The following is a description of a gene set: Genes gradually down-regulated by histamine in B16-F10 melanoma tumors. Mouse Gene Set: POS_RESPONSE_TO_HISTAMINE_DN from publication Pos Z, Wiener Z, Pocza P, Racz M, Toth S, Darvas Z, Molnar V, Hegyesi H, Falus A (PMID 18339882) studied in species Mus musculus We previously showed that transgenic enhancement of histamine production in B16-F10 melanomas strongly supports tumor growth in C57BL/6 mice. In the present study, gene expression profiles of transgenic mouse melanomas, secreting different amounts of histamine, were compared by whole genome microarrays. Array results were validated by real-time PCR, and genes showing histamine-affected behavior were further analyzed by immunohistochemistry. Regulation of histamine-coupled genes was investigated by checking the presence and functional integrity of all four known histamine receptors in experimental melanomas and by administering histamine H1 receptor (H1R) and H2 receptor (H2R) antagonists to tumor-bearing mice. Finally, an attempt was made to integrate histamine-affected genes in known gene regulatory circuits by in silico pathway analysis. Our results show that histamine enhances melanoma growth via H1R rather than through H2R. We show that H1R activation suppresses RNA-level expression of the tumor suppressor insulin-like growth factor II receptor (IGF-IIR) and the antiangiogenic matrix protein fibulin-5 (FBLN5), decreases their intracellular protein levels, and also reduces their availability in the plasma membrane and extracellular matrix, respectively. Pathway analysis suggests that because plasma membrane-bound IGF-IIR is required to activate matrix-bound, latent transforming growth factor-beta1, a factor suggested to sustain FBLN5 expression, the data can be integrated in a known antineoplastic regulatory pathway that is suppressed by H1R. On the other hand, we show that engagement of H2R also reduces intracellular protein pools of IGF-IIR and FBLN5, but being a downstream acting posttranslational effect with minimal consequences on exported IGF-IIR and FBLN5 protein levels, H2R is rather irrelevant compared with H1R in melanoma., and this is the list of marker genes: Med26, Eif2s2, Tatdn1, Mettl22, Klhl22, Dpm1, Asns, Cdt1, Ncor1, Gabpb1, Glyctk